The following is a description of a gene set: species: Homo sapiens Human Gene Set: JAZAG_TGFB1_SIGNALING_UP Genes up-regulated in PANC-1-puro cells (pancreatic cancer) stimulated by TGF1B for 2 h. from publication Jazag A, Ijichi H, Kanai F, Imamura T, Guleng B, Ohta M, Imamura J, Tanaka Y, Tateishi K, Ikenoue T, Kawakami T, Arakawa Y, Miyagishi M, Taira K, Kawabe T, Omata M (PMID 15592526) The transforming growth factor-beta (TGF-beta)-Smad signaling pathway inhibits the growth of human epithelial cells and plays a role in tumor suppression. The Smad4 gene is mutated or deleted in 50% of pancreatic cancers. In this study, we succeeded in establishing Smad4 knockdown (S4KD) pancreatic cancer cell lines using the stable RNA interference (RNAi) method. Smad4 protein expression was reduced dramatically and TGF-beta-Smad signaling was markedly inhibited in the S4KD cell lines. The S4KD and control cells were stimulated with TGF-beta and analysed using a cDNA microarray that contained genes, in order to screen for target molecules downstream of TGF-beta. The microarray analysis revealed that 187 S4KD genes and genes in the control cells were regulated immediately upon TGF-beta stimulation. Quantitative RT-PCR analysis on several of these genes produced results that corroborated the outcome of the microarray analysis. Most of the genes in the S4KD and control cells identified by the array differed, which suggests signaling pathways that differ according to Smad4 status. Of the identified genes, 246 have not been reported previously as genes that lie downstream of TGF-beta. Genes that are involved in cell proliferation, adhesion, and motility were found to be regulated differentially with respect to S4KD and control cells. Cell migration induced by TGF-beta was inhibited in the S4KD cells, which might be associated with a different regulation of integrin beta7. The knock down of a specific gene using stable RNAi appears to be a promising tool for analysing endogenous gene function., and this is the list of marker genes: SRCAP, RGS17, LPCAT3, RNF24, RAPGEF3, TGM5, CRABP2, PDZK1IP1, L1CAM, FSCN2, WBP4, AASS, ST8SIA4 (ST8 alpha-N-acetyl-neuraminide alpha-2,8-sialyltransferase 4), SLC12A7, SLC6A11, CCDC85B, ATF5, ABHD2, ERG28, CNIH1, SEC23IP, MRPS31, PTK7, ABCD1, STRAP, YAF2, FEZ2, FBXW10B, ALDOC, PTPN22, NEU3, LSM5, DVL3, FARS2, PRDX2, EBP, GFER, RASAL2, CASP3, PTPRH, NUDT21, VPS4A, SYNGR4, DNAAF11, GTF3C4, SEC22A, ATP6V0A2, PRELID1, CCNH, EHMT2, CSF2RB, HLA-A, PPP1R17, SLC22A7, KCNQ4, CNPY3, CCL5, CORIN, N6AMT1, WIF1, CELF2, GCM2, NUP50, KLRA1P, SLC35B1, DAP3, INSL6, BUD31, IL11, DSCR4, GTF2H2 (NCBI Gene Id 2966), CAPN9, PMP22, KIF4A, TOPORS, TIMM8B, NRG1, SPON2, CPSF4, IL9, HSF2BP, IL12A, SUPT16H, ITGB7, PLP1 (NCBI Gene Id 5354), MAP2K1, ILF3, PWP1, CCN6, PIGN, MED14, GMEB1, ABCB8, EMILIN1, ERLIN2, GPR75, BAG5, PKIG, CHORDC1, TIMELESS, KPNA6, CCPG1, GSR, TINF2, MT3, CCNE1